The following is a description of a gene set: studied in species Homo sapiens Catalysis of the reaction: JNKK + ATP = JNKK phosphate + ADP. This reaction is the phosphorylation and activation of JUN kinase kinases (JNKKs). Human Gene Set: GOMF_JUN_KINASE_KINASE_KINASE_ACTIVITY, and this is the list of marker genes: MAP3K11, LRRK2, MAP3K21, MAP3K20, RIPK2 (receptor interacting serine/threonine kinase 2), RIPK1, MAP3K9, MAP3K5 (NCBI Gene Id 4217), MAP3K10